Given this list of marker genes Ahnak, H2az1, Il7r, Tyrobp, Cd7, Crip1, here is a description of the gene set: Mouse Gene Set: CUI_NK_CELL_IL36A_RESPONSE_DN species: Mus musculus Cytokines mediate cell-cell communication in the immune system and represent important therapeutic targets. A myriad of studies have highlighted their central role in immune function, yet we lack a global view of the cellular responses of each immune cell type to each cytokine. To address this gap, the authors created the Immune Dictionary, a compendium of single-cell transcriptomic profiles of more than 17 immune cell types in response to each of 86 cytokines (>1,400 cytokine-cell type combinations) in mouse lymph nodes in vivo. A cytokine-centric view of the dictionary revealed that most cytokines induce highly cell-type-specific responses. For example, the inflammatory cytokine interleukin-1β induces distinct gene programmes in almost every cell type. A cell-type-centric view of the dictionary identified more than 66 cytokine-driven cellular polarization states across immune cell types, including previously uncharacterized states such as an interleukin-18-induced polyfunctional natural killer cell state. from publication Cui A, Huang T, Li S, Ma A, Pérez JL, Sander C, Keskin DB, Wu CJ, Fraenkel E, Hacohen N (PMID 38057668) Genes negatively differentially expressed in cell type: NK cell upon treatment with cytokine: IL-36α in mouse lymph nodes in vivo.